Given this list of marker genes HEATR5A (NCBI Gene Id 387979), GJC2, AP5M1, TMT1A, ANAPC16, COX14, APBB1, MYCT1, WDR5B, UQCRC2, ANAPC5, TMF1, DCK, FAM76B, ZNF473, HPS5, NCAPD3, LSM5, CCDC54, CKLF, PRKAR2B, GAPDHS, HEY2, PRODH2, NFYB, PPP1CC, COG5, ZNF600, POM121L12, MANSC1, SGPP1, NKAP, TCEAL9, PAIP2, SDHAF3, SYNPO2, PRMT2, MLANA, GSDMC, CLCN1, NAP1L5, MXD3, STMN1 (NCBI Gene Id 3925), GOLGB1, LAMC2, CEP70, PPM1N (NCBI Gene Id 147699), CHCHD1, THAP6, ADAMTS7, SACM1L (SAC1 like phosphatidylinositide phosphatase), UGT2B15, ELF1, RBP2, TEX47, TCTE1, DDX25, PDK4, TOP2B, NTS, SMC4, COL20A1, ENPP2, TTC39A, HEYL, NOXO1, WNT10A, KTN1, CD7, KHK, UNC93B1, CIAO1, BDH2, THEM5, MTMR14, AKAP6, PAQR3, BOK, SELENOK, GDPD1 (NCBI Gene Id 359824), SLC35A2, SFXN4, ARCN1, TBCD, STAM, DENND10, IDH3A, GIT2, NUP88, DMAC2L, TAF9B, COPZ1, NCKAP1L, MFF, TIFAB, SCD, CNBD2, UBE2T, BVES, BMP2, CNOT7, SERINC5, HOOK1, PILRA, GMCL1, VLDLR, CHD2, NDUFA12, ERC2, TRPM5, CCDC80, TRIQK, ANG, NAPSA, NUP205, PODXL2, CCNG1, RECQL, TCHH, CDC14A, CAT, DDX59, OARD1, PNPLA8, CTDSP2, ATXN1L, OSGEP, ERCC6L2, SYT6, ANP32A, PYGO1, ZMAT2, PJA2, TBC1D14, NIPSNAP2, ACOT9, PLSCR4, FAM120C, DIS3L2, CIB4, HNRNPA0, RBM10, ELMOD1 (ELMO domain containing 1), RPAIN, SECISBP2L, NELFCD, SLC39A12 (NCBI Gene Id 221074), TRIM62, CALCRL, KCNAB3, PPIH, TCEANC, AHSP, CEACAM21, CIAO2A, ECHDC1, PDZD9, EIF2B2, SMAP1, HMGCS1, EGFL7, DEDD, SOAT1, LRR1 (NCBI Gene Id 122769), SLC17A2, ZG16, PLEKHM3, THTPA (NCBI Gene Id 79178), NPTX1, SUCLA2, REXO4, IL17RD, CDIN1, STEAP4, NUPR1, DNAJC9, SMIM17, COPS6, VPS41, NGFR, NT5DC1, TGM1, FUBP3, GGN, KBTBD12, CENPC, GJB1, HEPACAM, CUL9, SCML2, BARD1, CORO6, SENP8, MYOZ3 (myozenin 3), SGCD, AFDN, TBXAS1, MMAB, VGLL2, FTMT, here is a description of the gene set: from publication Lee YK, Turner H, Maynard CL, Oliver JR, Chen D, Elson CO, Weaver CT (PMID 19119024) Human Gene Set: GSE14026_TH1_VS_TH17_DN This is to compare the gene expression profile of Th1 and Th17 cells. species: Homo sapiens Genes down-regulated in comparison of Th1 cells versus Th17 cells.